The following is a description of a gene set: Human Gene Set: GOCC_SMALL_SUBUNIT_PROCESSOME studied in species Homo sapiens A large ribonucleoprotein complex that is an early preribosomal complex. In S. cerevisiae, it has a size of 80S and consists of the 35S pre-rRNA, early-associating ribosomal proteins most of which are part of the small ribosomal subunit, the U3 snoRNA and associated proteins., and this is the list of marker genes: RPS3A, NOL10, FCF1 (FCF1 rRNA-processing protein), WDR43, MPHOSPH10, UTP15, UTP4, UTP20, NOL6, UTP18, NOP58, IMP4, RPS11, UTP14A, RPS23, C1orf131 (NCBI Gene Id 128061), AATF, RPS16, WDR75, SNU13, NOP14, RRP9, IMP3, RPS7, UTP14C, UTP3, RPS4X, RCL1, XRCC5, PDCD11, DNTTIP2 (NCBI Gene Id 30836), DIMT1, BMS1, RPS27A, FBL, NGDN, UTP23, DHX37, RPS5, NOP56, RPS17, PWP2, RPS6, RPS27, HEATR1, RPS15A, WDR36, DCAF13, NAT10, RPS13, UTP25, WDR46, PNO1, FBLL1, EMG1, RPS12, UTP11, RPS19, UTP6, KRR1, TBL3, NOC4L, NOL7, RPS8, RRP7A, RPS28, WDR3, RPS24, PRKDC, RPS19BP1, RPS9, RPS14, EXOSC10